Given this list of marker genes Echs1, Hadha, Hadh, Acads, Hadhb, here is a description of the gene set: Beta oxidation of hexanoyl-CoA to butanoyl-CoA studied in species Mus musculus Mouse Gene Set: REACTOME_BETA_OXIDATION_OF_HEXANOYL_COA_TO_BUTANOYL_COA